Given this list of marker genes NFKB2, RFXAP, BLM (NCBI Gene Id 641), C1GALT1C1, TAP2, FOXN1, STOX1, SP110, CARMIL2, RFX5, CD3E, SPINK5, SRP19, EGFR, SEC61A1, CORIN, CLPB, VPS33A, DOCK11, FOXP3, AICDA, SLC35C1, RFXANK, IFNGR1, TCIRG1, CIITA (NCBI Gene Id 4261), IRF9, TNFRSF13B, NFKBIA, CD3G, ADAT3, JAK3 (Janus kinase 3), DCLRE1C, ZAP70, GFI1, ELANE, ADAM17, IL21R, MAN2B1, COG4, NBN, FLT1, here is a description of the gene set: Human Gene Set: HP_RECURRENT_INFECTION_OF_THE_GASTROINTESTINAL_TRACT species: Homo sapiens Recurrent infection of the gastrointestinal tract Recurrent infection of the gastrointestinal tract.